Given this list of marker genes GBA1, NEU3, ARSF, M6PR, ARSG, ARSA, ARSL, GLA, HEXA, GLB1L3, SUMF1, GLB1L, SMPD3, NEU4, NEU2, PSAP, GALC, HEXB, GM2A, GLB1, GLB1L2, ARSJ (NCBI Gene Id 79642), GBA3, CTSA, ARSH, STS, GBA2, ARSD, SUMF2, SMPD4, ARSB, ARSI, ASAH1, ENPP7, SMPD2, SMPD1, NEU1, ASAH2, ARSK, here is a description of the gene set: Human Gene Set: REACTOME_GLYCOSPHINGOLIPID_CATABOLISM studied in species Homo sapiens Glycosphingolipid catabolism